The following is a description of a gene set: Mouse Gene Set: GOBP_CELLULAR_RESPONSE_TO_TYPE_II_INTERFERON species: Mus musculus Any process that results in a change in state or activity of a cell (in terms of movement, secretion, enzyme production, gene expression, etc.) as a result of an interferon-gamma stimulus. Interferon gamma is the only member of the type II interferon found so far., and this is the list of marker genes: Irf8, Gbp4, Il12b, Trp53, Rab43, Ccl5, Calm3, Igtp, Vps26b, Flnb, Adamts13, Evl, Kif5b, Actr2, Med1 (NCBI Gene Id 19014), Rab20, Epsti1, Rab11fip5, Arg1, Camk2a (NCBI Gene Id 98128), Daxx, Vamp4, Wnt5a, Zyx, Nlrc5, Sirpa, H2-Q7, Gbp2, Dapk1, Gapdhrt, Jak1, Aqp4, Cdc42ep2, Eprs1, Atl3, Rps6kb1, Capg, Gbp2b (NCBI Gene Id 677276), Ccl2, Stx8, Mir511, Txk, Acod1, Gapdh-ps15, Ciita, Irgm2, Pparg, Calm2, Jak2, Casp1, Rab7b, Irf1, Il12rb1, Stxbp3, Atl2, Myo18a, Stx4a (NCBI Gene Id 20909), Vamp3, Tyk2, Tlr2, Rab12, Was, Nos2, Tlr4, Gbp3, Stx11, Tlr3 (toll-like receptor 3), Ptpn2, Gbp8, Kif16b, Edn1, Cldn1, Cdc42, Gbp7, Cdc42ep4, Aif1, Gapdhrt2, Calm1, Rpl13a, Dnaja3, Slc26a6, Cd47, Tnf, Ass1, Stxbp1, Actg1, Gbp9, Otop1, Syncrip, Dapk3, Vim, Stxbp2, Actr3, Hpx, Star, Irgm1, Parp9, Pim1, Mst1, Slk, Pde12, Gbp6, Ifng, Gsn, Vamp8, Parp14, Mrc1, Fasl, Ifngr1 (interferon gamma receptor 1), Gbp10, Stxbp4, Gapdh (NCBI Gene Id 407972), Cdc37 (cell division cycle 37), Gbp5, Myo1c, Stat1